The following is a description of a gene set: studied in species Homo sapiens Genes predicted to be targets of miRBase v22 microRNA hsa-miR-6747-3p in miRDB v6.0 with MirTarget v4 prediction scores > 80 (high confidence targets). from publication Chen Y, Wang X (PMID 31504780) Human Gene Set: MIR6747_3P, and this is the list of marker genes: KDM3A, PHF24, SNPH, ARL5A, ORAI2, SHISAL1 (shisa like 1), MGAT3, UGP2, NKD1, AIDA, UAP1, TBX5, CLCN2, C2CD2, PRR15, AHDC1, RMDN1 (NCBI Gene Id 51115), NOVA2, LINGO2, CHRNA5 (cholinergic receptor nicotinic alpha 5 subunit), TLCD2, CAMK1D, AMZ1, NR6A1, PEAK1, DHRS3, KIDINS220, ACACA, PARD3B, MFSD6, POU2F1, TMEM72, BCL2L1, FRS2, AP5B1, ZNF629, CLIP2 (CAP-Gly domain containing linker protein 2), PBX1, MIDN, NIT1, IFNAR1, TSTD3, TMEM40, RAB11FIP4, PTPRH, AAK1, TLNRD1, KCNK6, KDM1B, INKA2, IL6R, PORCN, COL26A1, ZNF579, IQSEC3, CLK3, SPSB4, FA2H, AMOTL1, OPA3, POLR1E, NSD2, FAM222A, GAB2, KCNC1, GRAMD1B, RP9, GOLGA6L1, POLR2C, PGAP4, TIPRL, CBLN1, RAB6B (NCBI Gene Id 51560), GALNT6, APBA1 (amyloid beta precursor protein binding family A member 1), TMEM121B, B3GNTL1, CRTC1, EIF3L, PREB, PLAGL2, POM121C, KCTD1, EIF4G1, RHOV, TNNI1, CLIC5, DESI2, C6orf120, RXRA, ZFYVE16, UBXN7, CHMP4B, PPP1R3B, RTL9, MGAM2, PTPRZ1, ASXL1, SAMD8, SZRD1, CACNG8, KANSL3, ENSA, LY9, RFX3, BCORL1 (NCBI Gene Id 93949), CSMD2, TRIM56, ERC1, LINC02693, GOLGA6L6, ZER1, ATP11B, MBNL3, CTNS, NOS1, NECTIN2, ZNF346, ZNF516, CHRM1